The following is a description of a gene set: The differentiation of endothelial cells from progenitor cells during blood vessel development, and the de novo formation of blood vessels and tubes. Mouse Gene Set: GOBP_VASCULOGENESIS species: Mus musculus, and this is the list of marker genes: Pdgfrb, Myo18b, Gdf2, Pbrm1, Tie1, Egfl7, Aplnr, Ackr3, Ctnnb1, Yap1, Enpp1, Smarca4, Kdr, Rap1a, Junb, Cd34, Tgfbr3, Zfpm2, Hdac7, Rtn4, Hey1, Angpt1, Fbxw7, Ccm2, Myo1e, Foxf1, Adm, Shh, Epor, Wt1, Hoxa13, Xdh, Npr2, Cul7, T, Epo, Sgpl1, Wnt7b, Ptprj, Myocd, Itgav, Emp2, Cited2, Hhex, Tgfb1, Ptk2, Notch1, Rin2, Tgfbr2, Asb4, Fgfr1, Prok2, Gjc1, Egfl8 (EGF-like domain 8), Zfp36l1, Wnt7a, Hey2, Ntrk2, Rras, Zfp950, Cav1, Tead2, Heg1, Zmiz1, Fzd4, Tiparp, Cripto, Pitx2, Smo, Rapgef2, Itgb8, Ramp2, Sox18, Spred1, Rasip1, Sox17, Gata4, Fgfr2, Has2, Foxm1, Wars2, Tek (TEK receptor tyrosine kinase), Tnni3, Setd2, Brpf1, Amot, Epha2 (Eph receptor A2), Nrp1, Apela, Glmn, Paxip1, Fgf1, Fgf9, Tmem100, Nkx2-5, Ceacam1, Cited1, Qki, Eng